Given this list of marker genes MYD88, CEBPE, SCO2, TICAM1, IRF2BP2, RPL5, FOXP3, IGHM, TBL1XR1, LMBRD1, SMARCD2, TYMS, PIK3CD, IKBKG (inhibitor of nuclear factor kappa B kinase regulatory subunit gamma), TONSL, SRSF2, CTC1, FANCE, ASXL1, PACS2, PML, TFR2, IKZF1 (NCBI Gene Id 55429), SEC61A1, UNC13D, MPO, CARS1, FMO3, VPS33A, RAG1, RPL15, LYST, RPS29, CIITA, NDUFA6, ICOSLG, TSR2, MPLKIP, LRBA, TCIRG1, RPS26, RNF113A, TARS1 (NCBI Gene Id 94887), EPG5, TINF2 (TERF1 interacting nuclear factor 2), RTEL1, STX11, GALE, RPS28, MAD2L2, PCCB, PGM3, RPS27, CTLA4, C1GALT1C1, PIK3CG, KIT, NCAPG2, ANAPC1, PPIL1, NRAS, FCGR3B, SRP19, MTR, RELB, MVK, MMACHC, NCF1, G6PC3, STAT5B, CXCR2, TERC, SLC39A7, FANCD2, ARPC5, ABCD4, TET2, CAMK2B, SASH3, ELANE, RPL11, ACP5, MEFV, LIG4, IL7R (NCBI Gene Id 3575), ICOS, HEATR3, RPL18, MMAA, BTK, DOCK11, RPS14, LCP2, HLA-B, ERCC2, CD40, FBXW7, SH2D1A, SAMD9L, NABP1, CBL, LAMTOR2, CXCR4, RPL27, NPM1, SMARCAL1, FDX2, RPL9, XIAP, USB1, UHRF1, JAGN1, STAT3, BLNK, IFNG, AMN, ETV6, MMAB, GINS1 (NCBI Gene Id 9837), TAFAZZIN, TDP2 (tyrosyl-DNA phosphodiesterase 2), AGA, MMUT, STXBP2, RPS20, AP3D1, RFXANK, GTF2H5, STK4, ERCC3, PIK3R1, FANCC, CYBC1, UBE2A, SBDS, IL1RN, GTF2E2, SRP68, TMEM147, IRF8 (interferon regulatory factor 8), LBR, CSF3R, SFXN4 (sideroflexin 4), SLC37A4, GFI1, SF3B1, NCF2, IGLL1, NBAS, LRRC8A, CLPB, RUNX1, NCF4, CD79B, NOP10, SLC19A1, SPPL2A, RMRP, PRKAR1A (NCBI Gene Id 5573), FAS, CDC40, RECQL4, TLR8, CUBN, RARA, TRAC (NCBI Gene Id 28755), TRAF3, FNIP1, PCCA, IL6ST, HSCB, RPL35A, NHP2, MECOM, GPI, RFXAP, AK2, RPL26, FUT8, MTRR, PRDX1, GATA1, GSS, MDM4, KRAS, WAS, RPS10, SLC35A1, RPS7, VPS45 (vacuolar protein sorting 45 homolog), STAT4, RPS19, COG4, NSUN2, RFX5 (NCBI Gene Id 5993), IRAK4, CYBA (cytochrome b-245 alpha chain), STAT1, MSN (NCBI Gene Id 4478), NLRP3, AP3B1, SLC35C1, RPL8, FANCA, TBK1, PTPN6 (protein tyrosine phosphatase non-receptor type 6), HTRA2, PARN, ZNFX1, PMM2, WIPF1, TPP2, THPO, DIAPH1, AARS1, SAMD9, SPI1, DNAJC21, TERT, DKC1, WDR1, SLC46A1, SLC30A7, EIF2AK3, CD40LG, HELLS, ADA2, TCN2, RPL35, SRP54, MTHFD1, PNP, RAC2, TFRC, EFL1, FIBP, GATA2, FANCG, IL36RN, FANCI, TLR3, ZBTB16, NUMA1, RPL31, UNC93B1, RPS15A, HAX1, CASP10, MYSM1, VPS13B, PRF1, RAB27A, FASLG, RPS17, FBXL4, FTCD, ZBTB24, CRELD1 (NCBI Gene Id 78987), ATRX, BCOR, CYBB, CDCA7, FIP1L1, WRAP53, CD79A, ITCH, RPS24, OTULIN, TCF3, MYH9, DNMT3B, here is a description of the gene set: A neutrophil abnormality. Human Gene Set: HP_ABNORMALITY_OF_NEUTROPHILS Abnormality of neutrophils studied in species Homo sapiens